The following is a description of a gene set: The volume enclosed by the dense core granule membrane. species: Homo sapiens Human Gene Set: GOCC_DENSE_CORE_GRANULE_LUMEN, and this is the list of marker genes: IGF1, HCRT, CRH (corticotropin releasing hormone), PENK, VPS13A, GHRL